Given this list of marker genes Fgl2, Slamf8, Hspa8, Myd88, Pnp, Hprt1, Fcgr1, Clcn7, Sell, Ly6a, Irf1, Irgm2, Gbp9, Aig1, Ifi47, H2-T23, Cd300lf, Txn1, Ralgds, Gbp2, Pkib, Plac8, Irgm1, Batf2, Tpm3, Pkm, Cxcl9, Tmsb10, Tapbpl, Psmb9, Irf8, Gbp7 (NCBI Gene Id 229900), Acod1 (NCBI Gene Id 16365), Il18bp, Klrk1, Rnf19b, Serpina3f, Iigp1, Stx3, Phf11b, Fcgr4, Socs1, Hif1a, Fbxl5, Arpc2, Tspo, Snx10, Psmb10, Ccl12, Serpina3g, Gyg1, Stat1, Il27, Tnfaip2, Lcp2 (lymphocyte cytosolic protein 2), Ifi204, Stx11, Jpt1, Cmpk1, Clic4, Tap2, Skap2, Glrx, Ube2l6, Max, Gatm, Pfkp, Plaat3 (NCBI Gene Id 98147), Actg1, Psme2, Gbp3, Ifitm1, Bst1, Slfn1, Casp4, Psma5, Isg15 (NCBI Gene Id 53606), Cd69, Ppa1, Slc4a8, Tcf7l2, Tap1 (NCBI Gene Id 21354), Gbp5, Vamp8, Fgd2, Ddx17 (NCBI Gene Id 97974), Fam174a, Vim, Zbp1, Calhm6, Lap3, Zyx, Sdcbp, Ifit1, Nampt, Wars1, Tgm2, Bak1, Sod2, Tapbp, Il18rap, Samhd1, Psmb8, Cd274, Ly6c2, Cnn3, Naaa, Gbp4, Cxcl10, Igtp, Nlrc5, Ifi211, here is a description of the gene set: Genes positively differentially expressed in cell type: Monocyte upon treatment with cytokine: IFN-γ in mouse lymph nodes in vivo. from publication Cui A, Huang T, Li S, Ma A, Pérez JL, Sander C, Keskin DB, Wu CJ, Fraenkel E, Hacohen N (PMID 38057668) Cytokines mediate cell-cell communication in the immune system and represent important therapeutic targets. A myriad of studies have highlighted their central role in immune function, yet we lack a global view of the cellular responses of each immune cell type to each cytokine. To address this gap, the authors created the Immune Dictionary, a compendium of single-cell transcriptomic profiles of more than 17 immune cell types in response to each of 86 cytokines (>1,400 cytokine-cell type combinations) in mouse lymph nodes in vivo. A cytokine-centric view of the dictionary revealed that most cytokines induce highly cell-type-specific responses. For example, the inflammatory cytokine interleukin-1β induces distinct gene programmes in almost every cell type. A cell-type-centric view of the dictionary identified more than 66 cytokine-driven cellular polarization states across immune cell types, including previously uncharacterized states such as an interleukin-18-induced polyfunctional natural killer cell state. Mouse Gene Set: CUI_MONOCYTE_IFNG_RESPONSE_UP studied in species Mus musculus